The following is a description of a gene set: Human Gene Set: GOCC_CATALYTIC_STEP_2_SPLICEOSOME species: Homo sapiens A spliceosomal complex that contains three snRNPs, including U5, bound to a splicing intermediate in which the first catalytic cleavage of the 5' splice site has occurred. The precise subunit composition differs significantly from that of the catalytic step 1, or activated, spliceosome, and includes many proteins in addition to those found in the associated snRNPs., and this is the list of marker genes: HNRNPA1L3, PNN, DHX8, PPWD1, SRRM1, HNRNPF, SRSF1, CACTIN, DDX41, PRPF8, SYF2, HNRNPH1, CWC22, SNRNP200, BUD31, SLU7, LSM3, HNRNPR, SNRPG, SF3B2, TFIP11, DDX23, CDC40, RALY, DHX38, ESS2, SF3A3, MAGOHB, SYNCRIP, HNRNPA3, CWC15, PPIE, PPIL1, SART1, DDX5, HNRNPM, SNRNP40, CDC5L, LSM7, SF3B3, PPIL2, RBM44, SNRPD2, EFTUD2, PRPF6, SNRPD3 (NCBI Gene Id 6634), U2AF1, SNRPA1, DHX35, CRNKL1, GPATCH1, RBM8A, PABPC1, MTREX, CWC27, SNRPB, HNRNPC, HNRNPK, XAB2, PRPF19, SRRM2, PRP4K, HNRNPA2B1, MAGOH, ISY1, EIF4A3, HNRNPU, RBM22, PPIL3, HNRNPA1L2, RBMX, SNRPF, SNRPN, SNRPGP15, PLRG1, SNRPE, SF3B1, AQR, ALYREF, BCAS2, SNRPB2, FRG1, HNRNPA1, SNW1, SF3A1, WDR83, SNRPD1, ZCCHC8, LSM2, SF3A2